Given this list of marker genes KNL1, SEH1L, ACTR3, BRK1, YWHAE, H3C6, H4C13, CLASP1, MRTFA, ERCC6L, TUBB4B, RAC2, H4C4, NCKIPSD, ACTR2, SKA1, NCF2, H3C1, NUF2, H4C5, B9D2, H3C4, DVL2, TUBB8, ZWILCH, H4C6, YWHAG, H2BC4, RHOD, RANGAP1, H2AB1, SRGAP2, CALM1, CLASP2, MYH14, RTKN, PRKCD, TUBB2B, CENPA, H2BC3, ACTG1, NUP43, KLK2, AR, H2AC6, MAPK3, GOPC, NUP160, MYL12B, H3C13, CTNNA1, PIK3C3, YWHAB, NUP98, MAPK1, SRC, PPP2R1A, MYL6, H2BC11, PPP2CA, NOX3, RHOQ, PIN1, H3C14, KLK3, MAPK11, PTK2, INCENP, NCKAP1, H2AZ2, CENPC, BAIAP2, ABL1, FMNL3, H4C15, PFN2, H2AJ, RHPN2, KNTC1, MAPK14, ABI2, ROCK2, ITGB3BP, SPDL1, TUBA8, CYFIP1, PPP1CC, CENPL, PIK3R4, H2BC8, H2BC1, PPP1R14A, TUBB6, PRC1, H2BC21, TUBB4A, CENPK, NUP37, NCF4, NDC80, MAD2L1, MIS12, KIF2C, CENPM, CTTN, PAK3, DVL3, ARPC3, SGO2, ROCK1, ARPC1A, DLG4, H2BC13, KTN1, CFL1, H2BC5, CKAP5, DVL1, H2BC26, YWHAZ, CDCA8, TUBA1A, NCK1, MYLK, WASF1, H2AC14, DIAPH1, RHOC, MYL9, NSL1, H2BC6, FMNL1, KIF2B, PPP2R1B, H3C15, NCKAP1L (NCBI Gene Id 3071), WASF2, IQGAP1, NCOA2, H4C14, PMF1, DIAPH3, MAD1L1, SKA2, TUBA3D, PKN1, CENPO, PRKCA, CENPH, TUBB1 (NCBI Gene Id 81027), TAOK1, H2AC4, PPP1R12A, RHPN1, NF2, H4C1, NUDC, PRKCZ, PAK2, EVL, H3-3B, BUB3, H4C11, KLC4, CYBB, WASL, NOXO1, NUP85, DYNC1LI1, PFN1, MYH9, H4C2, H2BC14, TUBA3E, ARPC1B, TUBB8B, H2AC7, H3C12, KLC1, XPO1, CENPP, S100A8, CENPE, H2BC12, WIPF3, WIPF1, CDH1, TUBB3, RANBP2, NDEL1, WASF3, ZW10, NCF1, H2AC19, DYNC1I1, H3C2, PPP2R5D, SPC24, CENPI, DYNC1I2, KIF5A, KIF18A, RHOG, CDC25C, RCC2, KLC2, PAFAH1B1, H2AC18, MYH10, SCAI, H4C16, H3C11, SRF, PPP2R5C, DYNC1LI2, FMNL2, FLNA, H2BC15, H3C10, KIF5B, CENPU, RPS27, DYNLL2, AURKB, BUB1, MYH11, SEC13, CENPT, PDPK1, H2BC12L, NOX1, ACTB, TUBAL3, BIRC5, PPP1R12B, MAPRE1, TUBB2A, ARPC4, H4C12, CYBA, DSN1, YWHAH, CDKN1B, H2AC8, H3C3, DIAPH2, ITGB1, CTNNB1, H2BC17, CLIP1, ARPC2, IQGAP3, SFN, H3-3A, TAX1BP3, TUBA4B, DAAM1, ABI1, H2BC10, PPP1CB, PPP2R5A, CDC42, SPC25, KDM1A, PKN3, KIF14, ROPN1, CYFIP2, DYNC1H1 (dynein cytoplasmic 1 heavy chain 1), KLC3, NOXA1, LIN7B (lin-7 homolog B, crumbs cell polarity complex component), NUP107, CENPS, KDM4C, PRKCB, YWHAQ, BUB1B, PLK1, RHOB, DYNLL1, PPP2R5E, BTK, SGO1, WIPF2, PAK1, PKN2, LIMK2, NDE1, H4C3, H3C8, CENPQ, H3C7, CIT, PPP2R5B, RAC1 (NCBI Gene Id 5879), MEN1 (menin 1), LIMK1, TUBA3C, RHOA, TUBA1C, TUBA4A, CDC20 (cell division cycle 20), ARPC5, IQGAP2, H2AC20, CENPN, H4C8, CENPF, H2BC7, ZWINT, WAS, H2AX, PPP2CB, NUP133, TUBA1B, GRB2, H2BC9 (NCBI Gene Id 8345), H4C9, CFTR, KIF2A, S100A9, AHCTF1, here is a description of the gene set: studied in species Homo sapiens Human Gene Set: REACTOME_RHO_GTPASE_EFFECTORS RHO GTPase Effectors